The following is a description of a gene set: Human Gene Set: MEISSNER_BRAIN_HCP_WITH_H3K4ME2_AND_H3K27ME3 Genes with high-CpG-density promoters (HCP) bearing bivalent histone H3 dimethylation mark at K4 (H3K4me2) and trimethlation mark at K27 (H3K27me3) in brain. from publication Meissner A, Mikkelsen TS, Gu H, Wernig M, Hanna J, Sivachenko A, Zhang X, Bernstein BE, Nusbaum C, Jaffe DB, Gnirke A, Jaenisch R, Lander ES (PMID 18600261) DNA methylation is essential for normal development and has been implicated in many pathologies including cancer. Our knowledge about the genome-wide distribution of DNA methylation, how it changes during cellular differentiation and how it relates to histone methylation and other chromatin modifications in mammals remains limited. Here we report the generation and analysis of genome-scale DNA methylation profiles at nucleotide resolution in mammalian cells. Using high-throughput reduced representation bisulphite sequencing and single-molecule-based sequencing, we generated DNA methylation maps covering most CpG islands, and a representative sampling of conserved non-coding elements, transposons and other genomic features, for mouse embryonic stem cells, embryonic-stem-cell-derived and primary neural cells, and eight other primary tissues. Several key findings emerge from the data. First, DNA methylation patterns are better correlated with histone methylation patterns than with the underlying genome sequence context. Second, methylation of CpGs are dynamic epigenetic marks that undergo extensive changes during cellular differentiation, particularly in regulatory regions outside of core promoters. Third, analysis of embryonic-stem-cell-derived and primary cells reveals that 'weak' CpG islands associated with a specific set of developmentally regulated genes undergo aberrant hypermethylation during extended proliferation in vitro, in a pattern reminiscent of that reported in some primary tumours. More generally, the results establish reduced representation bisulphite sequencing as a powerful technology for epigenetic profiling of cell populations relevant to developmental biology, cancer and regenerative medicine. studied in species Mus musculus, and this is the list of marker genes: COMP, ARID3C, DUSP9, SHISA3, SPHK1, PPIC, NR4A3, KCNQ1, TCEA3, COL2A1, NRTN, ACAN, VGLL2, IHH, HTRA3, TSC22D3, USH1G, RAB37, TCP11, OXT, CHST6, TWIST1, FOXA1, TEAD2, GDF6, ARTN, LOXL2 (lysyl oxidase like 2), PITX2, ITGB4, IL27RA, SLC34A2 (solute carrier family 34 member 2), MAPK13, AQP3, MPIG6B, FLNC, HOXA1, TMPRSS2 (NCBI Gene Id 7113), CRABP1, PRPH, FAM83G, HROB, EMID1, VWA2, SLC6A4, TNFSF11, FOXI2, MCOLN2, BMP8A, HCK, ATOH1, VSX1, ILDR1, SOWAHD, LRRC15, WNT9B, LPAR3, GALR2, EOMES, SBSPON, LHX6